The following is a description of a gene set: Mouse Gene Set: GOBP_POSITIVE_REGULATION_OF_PROTEIN_LOCALIZATION studied in species Mus musculus Any process that activates or increases the frequency, rate or extent of a protein localization., and this is the list of marker genes: Itgb1bp1, Dlg4, Slc30a8, Tmem30b, Golph3l, Slc2a2, Wls, Snca, Trpa1, Gpsm2, Akap5, Abca12, Kif20b, Cemip, Pdx1, Prkci, Lepr (NCBI Gene Id 16847), Tnfaip6, Cacng2, Ptgs2, Glul, Ptn, Pecam1, Zfp384, Pck2, Rtn4, Camk2n1, Ghrl, Il13, Sqstm1, Adam22, Mlxipl, Agr2, Crh, Zdhhc1, Gpr137b, Wwtr1, Jak2, Cd38, Bad (BCL2-associated agonist of cell death), Flna, F2, Cct8, Lrp4, Pgrmc1, Gpr68, Il1a, Gpr39, Tomm70a, Abcg1, Rufy3, Edn1, Tardbp, Pik3ca, Zpr1, Fga, Anp32b, Gcg, Vrk1, Fcer1g, Fbxw7, Commd1, Camk1, Abcc8, Prkcd, Glis2, Mmp13, Cdc42, Cacna1d, Tnf, Oxct1, Stac, Hspa1l, Rab11a, Mief1, Blk, Nup62, C1qtnf3, Vsnl1, Pls1, Pdzk1, Wipf1, Myrip, Ssh1, Prkar1a (NCBI Gene Id 80472), Sirt6, Cd81, Cav2, Ogt, Dpp10, Npm1, Itpr1, Cep120, Gck, Larp7-ps, Wnk3, Nutf2-ps1, Tm9sf4, Itga3, Ano1, Brca1, Tcaf1, Rab34, Tenm1, Pinx1, Ang (NCBI Gene Id 11727), Adora2a, Ier3ip1, Pcsk1, Ubr5, Msn, Glud1, Gpd1l, Il6, Hpca, Erbb4, Tomt, Dtx3l, Kcnj11, Tsg101, Fis1, Lrrc8a, Tmem30a, Mesd, Fyn, Pkp1, Tlr2, Rac1, Erbb2, Vps28, Agap2, Serp1, Trim8, Prkcz, Rbp4, Oaz3, Cep250, Cdk5rap3, Stim1, Adcy8, Snx33, C2cd2l, Plk3, Cacnb4, Cyld, Ptpn23 (NCBI Gene Id 104831), Egfr, Rangrf, Oga, Ric3, Tgfb2, P2rx7, Myom1, Src, Ppm1a, Oaz2, Edem1, Itgb1, Xirp2, Cct7, Ppp1r9b, Ripor1, Syt11, Zfand1, Rfx6, Prkcb, Vegfa, Pparg, Rab38, Adam9, Epha3, Washc1, Zdhhc5, Pfkfb2, Ttn, Ang5, Actr3, Amotl2, Arrb1, Mpc2, Akt1, Cct6a, Abca7, Nr1h4, Farp1, Bag3, Ddrgk1, Apc, Trpc1, Nkx6-1, Tmed10, Dsg2, Pak1, Lrp2, Ergic3, Gnas, Mgat3, Gja1, Tyrobp, Cdkn2a, Asph, Smo, Ank3, Tfrc, Yap1, Tlr4, Ipo5, Tgfb3, Park7, Ctnnd1, Sptbn1, Vegfc, Hcar2, Ppia, Psen1, Pard6a, Nr1h2, Irs2, Jup, Egf, Ptpn5, Ifng, Hnrnpm, Pfkm, Ins1, Dpp6, Ipo7, Sesn2, Map1a, Gas8, Rack1, Trim28, Larp7, Nlgn3, Mtcl1, Gna11, Chp2, Prnp, Cd247, Cct3, Mief2, Tgfb1, Ankrd1, Tmed10-ps, Tyk2, Lamtor1, Dzip1 (DAZ interacting protein 1), Cct5, Osbp, Pcnt, Akt2, Nrxn1, Capn10, Pik3r1, Pdpk1, Myo5a, Hnrnpk, Epha2, Sfn, Nnat, Mff, Tek, Nlgn2, Dynll1, Ffar2, Hcls1, Chrm1, Ormdl3, Apoe, Glp1r, Tcp1, Pdcd5, Kcnb1, Snx27, Pcm1, Eif4g1, Dkc1, Rapgef4, Rph3al (rabphilin 3A-like (without C2 domains)), Psmd9, Vil1, Card10, Atg7, A1cf, Sybu (syntabulin (syntaxin-interacting)), Gas6, Sec24a, Abat, Baiap3, Nf2, Cep135, Nedd9, Plcb1, Ep300, Mark4, Casr, Ppid, Grip2, Gnai1 (NCBI Gene Id 14677), Stk11, Prkg2, Ppard, Ran, Mapk14, Ppp3cb, Zc3h12a, Malrd1, Cnpy4, Musk, Gsk3b, Cenpq, Trappc12, Iqgap1, F2rl1, Or51e2, Acsl4, Nlgn1, Bbc3, Ang4, Grin2a, Clstn3, Tunar, Nkd2, Sec16b, Myo1c, Cd2ap, Vamp8, Isl1, Gipr, Cln3, Parp1, Pias1, Prr5l, Golph3, Ice1, Slc35d3, Tnfrsf1a (tumor necrosis factor receptor superfamily, member 1a), Sirt3, Cct2, Efcab7, Zic1, Ang6, Trpm2, Kif3a, Myo18a, Cacnb3, Prkaa2, Rer1, Mcu, Slc5a3, Ap2b1, Myh10, Cenpj, Stx3, Cct4, Ccl2, Pdcd5-ps, Apbb1, Rock2, Cftr, Synj2bp, Nptn, Chrm3, Sorbs1, Tert, Hsp90aa1, Ephb2, Ect2, Dnm1l, Pmaip1, Hnf1a, Lamtor5, Pdcd10, Nr0b2, Ffar1, Acsl3, Aacs, Prkd1, Prkcq, Nmd3, Abhd17b, Prpf4b, Tcf7l2, Mepce, Rbm22, Clip3, Ptger4, Sh3glb1, Clasp2, Uaca, Arf1, Bsg, Gnaq, Rhog, Cdk5r1, Prkce, Vamp2, Sox4, Prkn, Cep295, Ezr, Camk4, Gpr27, Cdk5 (NCBI Gene Id 12568), Rapgef3, Hif1a, Xpo4, Fgb, Dsg3, Ptp4a3, Entr1, Mapt, Gpld1 (NCBI Gene Id 77224), Gsk3a, Slc51b, Emd, Numa1, Tomm7, Xbp1, Itgam, Eif3e, Abhd17a, Atp13a2, Stom, Mavs, Fgg, Ncoa6, Lrig2, Oaz1, Stac2, Parp9, Vps35, Tmem132a, Myh9, Tmem35a, Sorl1 (NCBI Gene Id 72910), Ccdc88a, App, Crocc, Eif2ak3, Ramp3, Limk2, Cdh1, B3gat3, Trh, Prkaa1 (NCBI Gene Id 105952), Ucn3, Ptpn22, Gip, Tent2, Fto, Jak1, Dok7, Arhgef16 (Rho guanine nucleotide exchange factor 16), Cfl1, Orai1, Hyal2, Wnt3a, Bcap31, Nadk, Frmd4a, Sirt1, Cdk1, Crebbp, Zdhhc2, Ang2, Pkp3 (plakophilin 3), Tm7sf3, Arpc2, Cep290, Stx4a, Pla2g6, Doc2b, Gli3, Dlg1, Wrap53, Bmp4, Arhgef5, Arf6, Agrn, Epb41, Atp2b4, Ngfr, Cib1, Bglap2, Myo5b, Gnl3l, Ptbp1, Chp1, Gper1, Pik3r2, Ywhae, Dmap1, Agt, Tpr, Cep131 (NCBI Gene Id 12009), Snap25, Sytl4, Crk, Rdx, Shh, Mapk1, Kif5b, Rab11fip2, Anxa7, Coro2b, Cdk9, Cacna1c (calcium channel, voltage-dependent, L type, alpha 1C subunit), Nutf2 (nuclear transport factor 2), Lep, Crkl, Necab2, Tesk1, Mcrs1, Meak7, Adcy10, Rab29, Hras, Cnst, Hcfc1, Ctdspl2, Lgals3, Tmem97, Trpm4, Epb41l2, Ins2, Gnl3, Dctn1, Nmu, C1qtnf12, Lrp1, Exph5, F2rl2, Trpm5, Pml, Ptpn9, Fnta, Abhd17c, Bicd1, Kcnn4, Stac3, Hdac3 (NCBI Gene Id 15183), Trem2, Mdm2, Atp2c1 (ATPase, Ca++-sequestering), Lrp5 (low density lipoprotein receptor-related protein 5), Edem2, Unc13b, Grip1, Hsp90ab1, Apbb3, Prkaca, Igf1, C2cd5, Fermt2, Cask, Gprc6a